The following is a description of a gene set: species: Homo sapiens Catalysis of the hydrolysis of phosphodiester bonds in chains of RNA. Human Gene Set: GOMF_RNA_NUCLEASE_ACTIVITY, and this is the list of marker genes: RNASEK, DCPS, RNASE3, ZC3H12B, ZC3H12A, ENDOU, APEX1, RNASE9, PAN3, RNASE7, ANKZF1, RNASET2, KHNYN, DIS3L2, NOB1, ENDOG, TOE1, NUDT16L1, EXO1, AGO4, REXO2, EXOSC5, ELAC1, LACTB2, RCL1, RNASE4, ERI3, PIWIL4 (NCBI Gene Id 192673), SLFN14, ERN1, SLFN13, DCP2, DBR1, ENDOV, PRORP, RPP30, PLD6, SMG6, AGO3, CPSF3, RNASEH2A, EXOSC10, MBLAC1, UBE3D, PIWIL1, RNASE12, RPP21, USB1, RPP40, MYG1, ABCE1, TSNAX, RNASEL, N4BP1, RPPH1, DIS3, EXOSC4, CNOT7, FEN1, ISG20, EXOSC1, ERN2, RNH1, RNASE1, RNASE6, MARF1, PNLDC1, RPP14 (ribonuclease P/MRP subunit p14), POP7, PDE12, TSEN2, AGO1, RNASE10, NYNRIN, ERI2, PAN2, ISG20L2, ELAC2, EXOSC9, POP5, CWF19L1, AZGP1, DIS3L, RNASE8, POLRMT, TMBIM6, PNPT1, YBEY, PIWIL2, ZC3H12D, EXD2, SLFN12, ZC3H12C, CNOT8, RPP25, EXOSC3, TSEN34, CNOT1, SAMHD1, INTS11, EXOSC2, ANG, PARN, EXOG, CNOT2, PPP1R8, RNASE11, EXOSC8, SND1, HELZ2, NOCT, MRPL44, NUDT16, AGO2, POP4, DROSHA, RNASE13, POP1, EXOSC7, RIDA, XRN2, DICER1, RNASE2, BRAT1, NUDT12, XRN1, RPP38, ERI1 (exoribonuclease 1), PIWIL3, EXOSC6, RNASEH1 (NCBI Gene Id 246243), CNOT6L, CNOT6